Given this list of marker genes Dio1, Dio2, here is a description of the gene set: part of: Thyroxine biosynthesis Reactome Pathway: Regulation of thyroid hormone activity This event has been computationally inferred from an event that has been demonstrated in another species.<p>The inference is based on the homology mapping from PANTHER. Briefly, reactions for which all involved PhysicalEntities (in input, output and catalyst) have a mapped orthologue/paralogue (for complexes at least 75% of components must have a mapping) are inferred to the other species. species: Mus musculus electronically inferred by orthology from the curated human pathway